The following is a description of a gene set: Human Gene Set: GOBP_NEGATIVE_REGULATION_OF_PEPTIDASE_ACTIVITY Any process that stops or reduces the rate of peptidase activity, the hydrolysis of peptide bonds within proteins. species: Homo sapiens, and this is the list of marker genes: SERPINB1, TIMP2, SPOCK3, FETUB, SERPINB9, SERPINB8, SERPINB13, ECM1, TIMP1, SERPINB4, SPOCK2, CR1, CRB2, EPPIN, RECK, UBXN1 (UBX domain protein 1), GAPDH, SERPINB3